The following is a description of a gene set: Human Gene Set: GOCC_CYTOPLASMIC_EXOSOME_RNASE_COMPLEX species: Homo sapiens A ribonuclease complex that has 3-prime to 5-prime processive hydrolytic exoribonuclease activity producing 5-prime-phosphomonoesters. Participates in a multitude of cellular RNA processing and degradation events preventing nuclear export and/or translation of aberrant RNAs. Restricted to processing linear and circular single-stranded RNAs (ssRNA) only. RNAs with complex secondary structures may have to be unwound or pre-processed by co-factors prior to entering the complex, esp if the 3-prime end is structured., and this is the list of marker genes: EXOSC10, EXOSC6, EXOSC7, EXOSC8, EXOSC5, GTPBP1, EXOSC4, EXOSC3, DIS3L, EXOSC1, EXOSC9, EXOSC2, CARHSP1, DIS3